Given this list of marker genes Poldip3, Mef2c, Vcp, Serp1, Mdga2, Kmt2a, Rnase6, Mfsd14a, C1qb, Fbxo30, Rheb, Adamts12, Ogfod2, Hspa5, Phf6, Rnf38, Cxadr, Dstyk, Ptafr, Rhoq, Khdc4, Mef2a, Kdm2a, Rnf11, Wtap, Eml1, Hells, Igsf1, Cd300e, Lats1, Prickle1, Ttll7, Slc25a46, Casq1, here is a description of the gene set: from publication Chen Y, Wang X (PMID 31504780) Mouse Gene Set: MIR_6953_3P Genes predicted to be targets of miRBase v22 microRNA mmu_miR_6953_3p in miRDB v6.0 with MirTarget v4 prediction scores > 80 (high confidence targets). species: Mus musculus